The following is a description of a gene set: The process in which relatively unspecialized cells of the ectoplacental cone acquire specialized structural and/or functional features that characterize chorionic trophoblasts. These cells will migrate towards the spongiotrophoblast layer and give rise to syncytiotrophoblasts of the labyrinthine layer. studied in species Mus musculus Mouse Gene Set: GOBP_CHORIONIC_TROPHOBLAST_CELL_DIFFERENTIATION, and this is the list of marker genes: Fzd5, Htra1, E2f7 (E2F transcription factor 7), Map3k4 (mitogen-activated protein kinase kinase kinase 4), Dnmt3l, Ascl2, E2f8